Given this list of marker genes Atmin, Pwwp3b, B230219D22Rik, Spty2d1, Rgs8, Arhgef28, Ets1, Mier3, Ankrd35, A130010J15Rik, Sema5a, Hdac2, Plppr4, Hnrnpa2b1, Itgb2, Nexmif, Map4k3, Sun1, Zfp526, Slc6a19, Arsk, Zfp579, Ap1s3, Tasor, Arid1b, E2f3, Ccser2, Pcp4, Tbr1, Tomm70a, Gtf2a2, Slc35e2, Arid4a, Adamts5, Sall3, Phaf1, Ypel2, Nfat5, Prkcb, Gm11715, Hsdl2, Efr3b, Bhlhe40 (basic helix-loop-helix family, member e40), Hoxd9, Dner, Scrn3, Esp31, Elavl2, Prpsap2, Pkdcc, Or7d10, Gpat4, Nudt11, Tcn2, Atf7, Fhip1b, Fam53c, Chst2, Cxcl2, Acsl4, Slc9a1, Tcaim, Gm14295 (predicted gene 14295), Ranbp6, Swi5, Smarcad1, Aak1, Eeig2, Clmn, Iqgap1, here is a description of the gene set: species: Mus musculus from publication Chen Y, Wang X (PMID 31504780) Genes predicted to be targets of miRBase v22 microRNA mmu_miR_742_5p in miRDB v6.0 with MirTarget v4 prediction scores > 80 (high confidence targets). Mouse Gene Set: MIR_742_5P